Given this list of marker genes SUSD4 (sushi domain containing 4), SND1, IRF4, ITGAV, LTBP2, WDR4, IL1R1, COPS8, UBE2H, LIMS1, STARD7, TBRG4, POGZ, TMBIM1, MSI2, GOLM2, RPL13, ELK3, FAM120A, OST4, SPR, ITPRID2, ACTR3, MID1IP1, KCNK6, LTBP4, NBPF20, TGOLN2, FNIP1, F2R, CLIC4, HDLBP, NDFIP1, CSNK1A1, SYT8, RABAC1 (Rab acceptor 1), PER2, MCUB, PRRX1, CDIPT, SLC20A1, PIP4P1, TAFA5, ZFAND5, RALBP1, ABI1, CUX1 (cut like homeobox 1), RAB3GAP2, CHMP4B, KCNQ1OT1, TGFB1, CHCHD2, C3orf70, PDE4A, PXDC1, ZNF622, CAPNS1, SRGAP2B, CREBRF, HIGD1A, RNASE4, BCAR3, KCNS3, PHLDA3, SLC39A1, SPSB1, MAOB, MTPN, TNS3, SLC26A2, EIF2S3, CHMP3 (charged multivesicular body protein 3), JUND, ATP1B1, LYNX1, COX4I1, CRLS1, EMP1, RSPRY1, PRXL2A, KIAA0040, KRT14, VAV2, TRA2A, ARHGEF2, ETF1 (eukaryotic translation termination factor 1), TXNIP, PEA15, PIK3R1, SUN2, USB1, CYB5A, CHSY1, AMD1, TLE5, TSC22D4, EDIL3, HAPSTR1, CREB3L2, SNAPC2, CHD2, TOMM20, SMAGP, RAB10 (RAB10, member RAS oncogene family), FKBP8, UGP2, MED13L, MSANTD3, VAPA, ATP6V1F, SFT2D2 (SFT2 domain containing 2), MAPK6, CCDC71L, SNTA1, INHBA, SREBF2, ZBTB16, C1orf21, OBSL1, FSTL3, BGN, DSG2, YOD1, VMA21, TMEM214, NR3C1, KDSR, CAPN2, KLF7, CAST, MBNL1, GLS, PCBP1, CDA, COQ10B, ABI2, MRPS21, SOCS2, SET, RBM3, IL6R, ASH1L, HAGHL (NCBI Gene Id 84264), ZKSCAN1, MEF2D, BRI3, NORAD, HAX1, B4GALT1, BROX, RPS17, WDR26, PHF5A, APP, ARRDC1, MCL1, ARHGAP5, MPZL1, MLPH, KAT5, RNF115, C1orf198, PACSIN2, C1orf56, BCL2L1, CRYAB, ACIN1, SECISBP2L, SRPX2, ABL2, MAFK, SAA1, NAV1, NGEF, KHDC4, SQLE, PRKAB2, BRMS1L, AIDA, CLTB, PARVB, MYO1E, TPST1, HMGXB3, FAM118A, UPK3BL1, ZNF430, A4GALT, CBX3, CAV2, SCN1B, GCC2, ENTPD2, CMIP, YWHAG, DIXDC1, SLC35E4, ARL5A, NFIX, TMEM248, B3GNT7, AFTPH (NCBI Gene Id 54812), SYNPO, CYB5R3, GCNT1, ANKRD11, KLF9, ARL8A, MTMR11, WDR33, PAIP2, CCNO, DSC3 (NCBI Gene Id 1825), CHPF, SORBS2, RBMS1, SDC4, ERF, BNIP2, HEBP2, PPIG, PTPN14 (NCBI Gene Id 5784), SERF2, EIF5B, BOK, PODNL1, DNAJB6, MVD, EXOC3, CNFN, CSNK1E, CARM1, EMX2, XYLT1 (xylosyltransferase 1), NFIC, RAB7A, E2F4, TCEAL9, EIF3L, SIK1, EZR, MBD1, BRD4, OTUD7B, FAM177A1, ELN, LTC4S, NCKAP1, GPN1, DGUOK, HBP1, IQGAP1, FAH, TLK1, ATP8B2, LOXL3, RBFA, OSBPL1A, SNHG15, SNX5, RBFOX2, CSDC2, CDK6 (NCBI Gene Id 1021), SERTAD2, H1-2, TNFAIP8L3, TRIP10, HOMER3, COPA, NFATC2, CAMK2N1, PMAIP1 (NCBI Gene Id 9305), CYTOR, BIN1, IVNS1ABP, RTN4, TJP1, TIAM1, RPL17, MPG, CD55, TMEM208, NGRN, FAM210B, ITSN2, CYBRD1 (NCBI Gene Id 79901), TFPT, UHMK1, ANXA4, FOXA2, TMEM183A, PDK4, RTL8C, SPG21 (SPG21 abhydrolase domain containing, maspardin), PRKAR2B, H1-0 (NCBI Gene Id 3005), VASP, SBDS, MORF4L1, UBE2Q2, C5orf24 (NCBI Gene Id 134553), DPP7, RAB11FIP5, SHC1, GPR153, GATAD2B, VAMP4, TGM2 (transglutaminase 2), KDELR3, CCZ1, YY1AP1, FOXC2, ABLIM3 (actin binding LIM protein family member 3), VWC2, ZBTB43, KDELR2, PIM3, AHNAK2, ZC3H15, POLD2, GNB1, SREK1, CCDC68, EPS8, CSTB (NCBI Gene Id 1476), COL14A1, KMT2E, MMP24OS, GDI1, PPP1R1B, TMEM63A, ADGRG1, HIP1, UBQLN1, MTA3, ATP1A1, FLOT1, MAP3K2, CFL2 (cofilin 2), RBM39, TIMM10B, PTPN18, SLC12A4, TMEM204, JTB, AXL, ZBTB7A, CAMSAP2, STAU1 (NCBI Gene Id 6780), EGFL7, RABGGTB, ACP1, TOR1AIP2, FBXO7, JAG1, TNS1, MAP1LC3A, PTPA, FAM89A, SEC23A, EVA1C, GOLPH3, PRR5, ATP6V1G1, TIMM17A, NBPF15, LARP1, FHL3, CIC, SEZ6L2, RBBP6, RTF1, ENSA, PLAGL1, GAS7, C1orf43, RHOT2, CNOT9, CHST8, TSPO (translocator protein), BFAR, MKRN1, TSTD1, LRRC8A, PRRC2C, KANSL1L, LCAT, IMPDH1, HNRNPU, ITGA10, COL7A1, DPM1, NCK2, DDX17, BLZF1, IL16, ARPC2, CBFB, RPS21, DESI2, IFRD1, HNRNPH1, DNER, RPS27A, RAPH1 (Ras association (RalGDS/AF-6) and pleckstrin homology domains 1), CMTM3, FBXW5 (NCBI Gene Id 54461), PELI1, RPS28, FKBP5 (FKBP prolyl isomerase 5), GSN, COL16A1, MAPKAPK2, ETHE1, TAPBP, DAP, SUN1, ZFHX3, STK38L, ITGA5, CTTN, COL27A1, BCL6, GTF2I, GPSM1, TOP1, JADE1, PSMD4, UBE2B, SH3BP4, APH1A, TMEM47, LIX1L, STXBP6, CDC73, BMP7, MIR4435-2HG, NBPF11, GSPT1, EPAS1, HMGCS1 (3-hydroxy-3-methylglutaryl-CoA synthase 1), LITAF, SYNE2, DDX42, CRIM1, SPTSSA, RNF145, ARID4B (NCBI Gene Id 88087), NIBAN2, MAP1B, SNHG7, TCF25, MYADM, CDC42EP3, CD109, CD46, SEC61B, CHP1, CAPS, PPP1R14B, KDM3B, PITPNB, TYRO3, HABP4 (NCBI Gene Id 22927), TTLL4, WASL, SPRY2, WHRN, PRUNE2, ESYT2, SAMD4B, FOXO3, CCND3 (cyclin D3), CBX6, KLF13, CYSTM1, PAPPA, ZDHHC9, SNN, H2BC21, IDS, NUCB1, AFF4, SHC4, ASS1, NDUFA4, RNF144A, MT-ND4L, MTURN, COBLL1, DDX1, SRRM2, H2AC25, MEF2A, COPS2, C1orf35, UGDH, SPOCK1, ATN1, RIOK3, MYH9, ADAR, RPLP1, MGST3, TOX4 (NCBI Gene Id 9878), RNF126, TWIST2, CDC42SE1, WTAP, TRABD, TSC22D3, CALB2, CEBPB, FAM180A, ENTREP3, DAAM2, here is a description of the gene set: from publication Su Z, Ho JWK, Yau RCH, Lam YL, Shek TWH, Yeung MCF, Chen H, Oreffo ROC, Cheah KSE, Cheung KSC (PMID 38267611) studied in species Homo sapiens Human Gene Set: SU_HO_CONV_CENT_CHONDROSARCOMA_C1_HIGH_GRADE_CHONDROSARCOMA_2 The transformation of benign lesions to malignant tumours is a crucial aspect of understanding chondrosarcomas, which are malignant cartilage tumours that could develop from benign chondroid lesions. However, the process of malignant transformation for chondroid lesions remains poorly understood, and no reliable markers are available to aid clinical decision-making. To address this issue, we conducted a study analysing 11 primary cartilage tumours and controls using single-cell RNA sequencing. By creating a single-cell atlas, we were able to identify the role of endoplasmic reticulum (ER) stress in the malignant transformation of conventional central chondrosarcomas (CCCS). Our research revealed that lower levels of ER stress promote chondrosarcoma growth in a patient-derived xenograft mouse model, while intensive ER stress reduces primary chondrosarcoma cell viability. Furthermore, we discovered that the NF-?B pathway alleviates ER stress-induced apoptosis during chondrosarcoma progression. Our single-cell signatures and large public data support the use of key ER stress regulators, such as DNA Damage Inducible Transcript 3 (DDIT3; also known as CHOP), as malignant markers for overall patient survival. Ultimately, our study highlights the significant role that ER stress plays in the malignant transformation of cartilaginous tumours and provides a valuable resource for future diagnostic markers and therapeutic strategies. Major neoplastic cell cluster of High_2 tumors. Expressed TGFBI, a key player in tumour invasion and metastasis, ITGA10 (a prognostic marker and therapeutic target for myxofibrosarcoma ), and EZR (a cell adhesion myosin regulating tumour proliferation and metastasis ).